Given this list of marker genes ING5, RBBP4, PIP4K2A, PIP4K2C, PIP4P1, TP53, MBD3, HDAC1, BRD1, PML, PIP4K2B, MAP2K6, CHD4, PIN1, HDAC2, AKT1, AKT2, BRPF3, GATAD2A, MTA2, EP300, KAT6A, MEAF6, RBBP7, GATAD2B, BRD7, ING2, AKT3, BRPF1, CHD3, here is a description of the gene set: Human Gene Set: REACTOME_REGULATION_OF_TP53_ACTIVITY_THROUGH_ACETYLATION Regulation of TP53 Activity through Acetylation studied in species Homo sapiens